The following is a description of a gene set: Posterior displacement of the tongue into the pharynx, i.e., a tongue that is mislocalised posteriorly. Human Gene Set: HP_GLOSSOPTOSIS Glossoptosis species: Homo sapiens, and this is the list of marker genes: GNAI3, MYMK, NFASC, SNRPB (small nuclear ribonucleoprotein polypeptides B and B1), AFF4, RBM10, COG1, TCOF1, FLNA, FIG4, CHD6, EDNRA, RUNX2, SOX9, COL2A1 (NCBI Gene Id 444981), NFIX, POLR1D, EDN1, BTK, BMP4 (bone morphogenetic protein 4), SLC35B2, TGDS, POLR1B, COL11A1, PEX16, PLCB4, VAC14, HDAC9, POLR1C, RSPO2, MYMX, COL11A2 (collagen type XI alpha 2 chain)